Given this list of marker genes RNF141, GRAMD1C, H2AZ2, KBTBD7, FCHO2, LINC01215, IGF1R, RRAGD, STEAP4, SGK1, TP53INP1, ITM2A, IRS2 (insulin receptor substrate 2), TMCC3, CXCL8 (NCBI Gene Id 3576), PDZD8, DPY19L3, CEP68, DIP2A, SH3YL1, STXBP5, RUNX2, FRY, ABAT, CAMK1D, FCER1A, PIGX, CD24, RFLNB (refilin B), THBD, BRI3BP, GPR27, here is a description of the gene set: Human Gene Set: ERWIN_COHEN_BLOOD_VACCINE_TC_83_AGE_23_48YO_VACCINATED_VS_CONTROL_2DY_DN Genes down-regulated in blood vaccinated vs control in adults (23-48) after exposure to Live attenuated vaccine TC-83, time point 2D Venezuelan equine encephalitis virus (VEEV) is an important human and animal alphavirus pathogen transmitted by mosquitoes. The virus is endemic in Central and South America, but has also caused equine outbreaks in southwestern areas of the United States. In an effort to better understand the molecular mechanisms of the development of immunity to this important pathogen, we performed transcriptional analysis from whole, unfractionated human blood of patients who had been immunized with the live-attenuated vaccine strain of VEEV, TC-83. We compared changes in the transcriptome between naive individuals who were mock vaccinated with saline to responses of individuals who received TC-83. Significant transcriptional changes were noted at days 2, 7, and 14 following vaccination. The top canonical pathways revealed at early and intermediate time points (days 2 and 7) included the involvement of the classic interferon response, interferon-response factors, activation of pattern recognition receptors, and engagement of the inflammasome. By day 14, the top canonical pathways included oxidative phosphorylation, the protein ubiquitination pathway, natural killer cell signaling, and B-cell development. Biomarkers were identified that differentiate between vaccinees and control subjects, at early, intermediate, and late stages of the development of immunity as well as markers which were common to all 3 stages following vaccination but distinct from the sham-vaccinated control subjects. The study represents a novel examination of molecular processes that lead to the development of immunity against VEEV in humans and which may be of value as diagnostic targets, to enhance modern vaccine design, or molecular correlates of protection. from publication Erwin-Cohen RA, Porter AI, Pittman PR, Rossi CA, DaSilva L (PMID 27870591) studied in species Homo sapiens